Given this list of marker genes Dhdds, Sars2, Ccdc198 (coiled-coil domain containing 198), Ccdc43, Tmc7, Rab26, Rdh5, Stac2, Topbp1, Rab40b, Cd38 (CD38 antigen), Zfc3h1, Arhgef37, Tmem150b, Prkab2, Cdk5r2, Bard1, Scarb1 (scavenger receptor class B, member 1), Lipk, Ddias, Sash3 (NCBI Gene Id 74131), Amotl1, Synpo2l, Slfn8, Mpp7, Dexi, Ildr2, Klf14, Trub2, Pecam1, Ssh2, Tcf25, Gk, Sec14l1, Usp4, Golga7b, Asxl3, Slc25a34, Eef2k, Cenpu, Ptpa, Sgcg, Maged1, Vwa1, Psmd9, Nicn1, Tnrc6b (NCBI Gene Id 72625), Il23r, Adamts15, Amer3, Tub, Dpm2, Plin5, Ky, H13, Hapln4, Spesp1, Rpf2, Usp7, Slfn9, Aak1, B3gnt9, Gfap, Fbxw7, Mief1, here is a description of the gene set: from publication Chen Y, Wang X (PMID 31504780) species: Mus musculus Mouse Gene Set: MIR_6947_3P Genes predicted to be targets of miRBase v22 microRNA mmu_miR_6947_3p in miRDB v6.0 with MirTarget v4 prediction scores > 80 (high confidence targets).